Given this list of marker genes Cltb, Chmp4b, Fas, Mxd1, Etv6, Myl12b, Nars1, Rnf213, Junb, Il6ra, Ppa1, Ly6a, Stat1, Flot1, Fam241a, Birc3, Igtp, Psme1, Serpinb6b (serine (or cysteine) peptidase inhibitor, clade B, member 6b), Zfp36, Socs3, Gpr146, Tapbp, Parp14, Il6st, Serpinb1a, Ptpn1, Myd88, Cpne3, Cars1, Sdf4, Il4ra, Gbp5 (guanylate binding protein 5), Parp9, Cd82, Arid5a, Arid5b, Rab18, Ssh2, Cdkn2d, Ldha, Gzmb, Satb1, Eif1, Mthfd2, Igfbp4, Klhl6, Psma2, Ifi35, Sema4d, Dtx3l, Rtp4, Abi3, Tpst2, Zfp36l2, Vps37b, Bst2, Pim1, Bcl3, Gpr18 (NCBI Gene Id 263515), Lamp2, Ptma, Zbp1, Tsc22d3, Gadd45g, Rapgef6, Ifi27l2a, Trac, Kri1, Fkbp5, Vars1 (NCBI Gene Id 22321), Gngt2, Iigp1, Psmb10, Txnip, Gbp2, Isg15, Frmd4b, Ifngr1, Cebpb, Gpr171, Ddit3, Xaf1, Samsn1, Tcf7, Il7r, Serinc3, Sgk1, Samhd1, Iars1, Rbm3, Nfkbiz, Mapkapk2, Elovl6, Cd53, Sbno2, Ly6e, Ran, Sipa1l1, Gzma, Cyfip2, Ndrg3, Trpc4ap, Crlf2, Mcl1, Rras2, Eif1a, Il21r, Treml2, Aars1, Clic4, Pja1, Batf, Tpm3, Plekho1, Macir, Jund, Socs1, Irf7 (NCBI Gene Id 54123), Psma7, Sell, Tspan13, Skap2, Eeig1, Klf13, Mrpl52, Apobec3, Icam1, Lsm4 (LSM4 homolog, U6 small nuclear RNA and mRNA degradation associated), Sumo2, Dad1, Ppp1r16b, Agfg1, Kif1b (NCBI Gene Id 16561), Shmt2, Pgs1, Ifi47, Ablim1, Zfp281, Eif5a, Stat3, Psme2, Akt2, Gpr65, Smc1a, Slc49a4, Oas3, Arl6ip5, Phgdh, Eif2s2, Plac8, Map3k8, Zfp1, Cytip, Camk2d (calcium/calmodulin-dependent protein kinase II, delta), Nup210, Emb, Trim30a, Isg20, Serpinb9, Cyb5a, Ppm1h, Hivep2, Ube2d3, Ankrd11, Gbp4, Grk6, Gramd2b, Nfkbia, Tgfbr2, Rrp1b, Runx3, Ssbp4, here is a description of the gene set: Cytokines mediate cell-cell communication in the immune system and represent important therapeutic targets. A myriad of studies have highlighted their central role in immune function, yet we lack a global view of the cellular responses of each immune cell type to each cytokine. To address this gap, the authors created the Immune Dictionary, a compendium of single-cell transcriptomic profiles of more than 17 immune cell types in response to each of 86 cytokines (>1,400 cytokine-cell type combinations) in mouse lymph nodes in vivo. A cytokine-centric view of the dictionary revealed that most cytokines induce highly cell-type-specific responses. For example, the inflammatory cytokine interleukin-1β induces distinct gene programmes in almost every cell type. A cell-type-centric view of the dictionary identified more than 66 cytokine-driven cellular polarization states across immune cell types, including previously uncharacterized states such as an interleukin-18-induced polyfunctional natural killer cell state. studied in species Mus musculus from publication Cui A, Huang T, Li S, Ma A, Pérez JL, Sander C, Keskin DB, Wu CJ, Fraenkel E, Hacohen N (PMID 38057668) Mouse Gene Set: CUI_T_CELL_CD8_IL1A_RESPONSE_UP Genes positively differentially expressed in cell type: CD8+ T cell upon treatment with cytokine: IL-1α in mouse lymph nodes in vivo.